The following is a description of a gene set: The directed movement of hexose phosphate into, out of or within a cell, or between cells, by means of some agent such as a transporter or pore. species: Mus musculus Mouse Gene Set: GOBP_HEXOSE_PHOSPHATE_TRANSPORT, and this is the list of marker genes: Slc37a4, G6pc1, Slc37a1, G6pc3, Slc37a2